Given this list of marker genes LSM1, EXOSC7, CNOT7, EIF4G1 (eukaryotic translation initiation factor 4 gamma 1), HBS1L, SKIC3, EXOSC3, DIS3, LSM3, SKIC8, EXOSC4, LSM2, NT5C3B, DCP2, EIF4A2, CNOT4, PABPC1 (poly(A) binding protein cytoplasmic 1), DCP1A, PAN2, CNOT8, DCP1B, EIF4E, EXOSC1, EDC4, PAIP1, CNOT1, PARN, EXOSC8, EXOSC6, LSM7, XRN1, EDC3, EXOSC2, EIF4A1, SKIC2 (SKI2 subunit of superkiller complex), EIF4B, EXOSC9, CNOT11, PAN3, CNOT2, LSM5, CNOT10, LSM4, TUT7, LSM6, CNOT6L, EXOSC5, CNOT6, PATL1, TUT4, TNKS1BP1, DCPS, EIF4A3, CNOT3, DDX6, CNOT9, here is a description of the gene set: Reactome Pathway: Deadenylation-dependent mRNA decay After undergoing rounds of translation, mRNA is normally destroyed by the deadenylation-dependent pathway. Though the trigger is unclear, deadenylation likely proceeds in two steps: one catalyzed by the PAN2-PAN3 complex that shortens the poly(A) tail from about 200 adenosine residues to about 80 residues and one catalyzed by the CCR4-NOT complex or by the PARN enzyme that shortens the tail to about 10-15 residues.<br>After deadenylation the mRNA is then hydrolyzed by either the 5' to 3' pathway or the 3' to 5' pathway. It is unknown what determinants target a mRNA to one pathway or the other.<br>The 5' to 3' pathway is initiated by binding of the Lsm1-7 complex to the 3' oligoadenylate tail followed by decapping by the DCP1-DCP2 complex. The 5' to 3' exoribonuclease XRN1 then hydrolyzes the remaining RNA.<br>The 3' to 5' pathway is initiated by the exosome complex at the 3' end of the mRNA. The exosome processively hydrolyzes the mRNA from 3' to 5', leaving only a capped oligoribonucleotide. The cap is then removed by the scavenging decapping enzyme DCPS. species: Homo sapiens part of: Metabolism of RNA